The following is a description of a gene set: Any process that modulates the frequency, rate or extent of the directed movement of iron ions (Fe) from one side of a membrane to the other by means of some agent such as a transporter or pore. Mouse Gene Set: GOBP_REGULATION_OF_IRON_ION_TRANSMEMBRANE_TRANSPORT species: Mus musculus, and this is the list of marker genes: Iscu, Hamp2, Heph, Hamp, Nos1, Ifng, Atp7a, Lcn2